Given this list of marker genes DDX3X (DEAD-box helicase 3 X-linked), TSSK2, NSD3, BCL11A, IGFBP5, LRRC4, BAZ2B, PRIMA1, CACNA1C, ADAM9, PDGFRA, ZNF608, SYT6, ZNF182, CHD4, SENP1, SOX4, SLMAP, USP6, API5, GDF6, R3HDM1, PHYHIP, CSK, ZNF654, C1orf21, RNF19A, ABRAXAS2, SIAH1, EHD1, VEGFA, DIPK2A, LRRC8E, PPP1CC, BACH1, YES1, STAG1, ETV3, BCL2L2, KCND2, DPP4, ACTN4, SAMTOR, GYS1 (NCBI Gene Id 2997, glycogen synthase 1), BCL9, OSTM1, SNX2, GALNT16, MDGA2, DDX3Y, EYA2, TBX3, TAF9B, KATNBL1, SRR, SLC41A2, MEX3C, STRADB, REEP1, ERC2, CSNK1G3, ABCC4, TP53INP2, DTNA, CIT (NCBI Gene Id 11113), HNRNPH3, TTYH2, E2F3, HDAC4, DBNDD2, SLC38A2, ZBTB10, HSPA13 (NCBI Gene Id 6782), ACVR1, ATOSA, EPHB1, DAZL, RTKN2, AMER2, MAP3K8, MGAT1, UBASH3B, DSCAM, ANK2, PFN1, CUL3, MOK, ZBED4, SLC25A13, DCUN1D4, OGT, NKIRAS2, TSPAN2, ADAMTS5, NR3C1, SLF2, NUTF2 (nuclear transport factor 2), DHX57, WNT1, PHF20L1, LOXL3, PITX2, COL23A1, CTCF, TSHZ1, GABARAP, GIT1, CEBPA, MMD, NAV3, here is a description of the gene set: Human Gene Set: AAACCAC_MIR140 Genes having at least one occurence of the motif AAACCAC in their 3' untranslated region. The motif represents putative target (that is, seed match) of human mature miRNA hsa-miR-140 (v7.1 miRBase). species: Homo sapiens